The following is a description of a gene set: The process in which a cell becomes capable of differentiating autonomously into an oligodendrocyte in an environment that is neutral with respect to the developmental pathway. Upon specification, the cell fate can be reversed. studied in species Mus musculus Mouse Gene Set: GOBP_OLIGODENDROCYTE_CELL_FATE_SPECIFICATION, and this is the list of marker genes: Ascl1, Sox6, Nkx2-2, Olig2, Pax6